The following is a description of a gene set: species: Homo sapiens Any process that stops, prevents, or reduces the frequency, rate or extent of dendrite morphogenesis. Human Gene Set: GOBP_NEGATIVE_REGULATION_OF_DENDRITE_MORPHOGENESIS, and this is the list of marker genes: DPYSL5, PPP3CA, NFATC4, RAPGEF2, GORASP1, TRPC5, TRPC6, TLX2, YWHAH